The following is a description of a gene set: Reactome Pathway: Glutamate binding, activation of AMPA receptors and synaptic plasticity studied in species Homo sapiens Excitatory synaptic transmission in the brain is carried out by glutamate receptors through the activation of both ionotropic and metabotropic receptors. Ionotropic glutamate receptors are of three subtypes based on distinct physiologic properties and their differential binding of exogenous ligands namely NMDA (N-methyl D-aspartate), AMPA (alpha-amino-3-hydroxy-5-methyl-4-isoxazolepropionic acid) and Kainate. The ionotropic receptors are glutamate gated ion channels that initiate signaling by influx of ions, and are comprised of subunits with distinct structures and distinguished based on their agonist binding. Even though all three types of receptors are found at the glutamatergic synapses yet they exhibit great diversity in the synaptic distribution. The metabotropic glutamate receptors are a family of G-protein coupled receptors that are slow acting. Fast excitatory synaptic transmission is carried out through AMPA receptors. Post-synaptic transmission involves binding of the ligand such as glutamate/AMPA to the AMPA receptor resulting in the Na influx which causes depolarization of the membrane. NMDA receptors are blocked by Mg at resting membrane potential. NMDA receptors are activated upon coincident depolarization and glutamate binding are activated following AMPA receptor activation.NMDA receptors are blocked by Mg at resting <br>membrane potential. NMDA receptors are Ca permeable and their activity leads to increase in Ca which, leads to upregulation of AMPA receptors at the synapse which causes the long lasting excitatory post-synaptic potential (EPSP) which forms the basis of long term potentiation (LTP). LTP is one form of synaptic plasticity wherein the strength of the synapses is enhanced by either change in the number, increase in the efficacy by phosphorylation or change in the type of receptors. Phosphorylation of AMPA receptors changes the localization of the receptors, increases the single channel conductance, and increases the probability of open channel. GluR1 has four phosphorylation sites; serine 818 (S818) is phosphorylated by PKC and is necessary for LTP, serine 831 (S831) is phosphorylated by CaMKII that increases the delivery of receptors to the synapse and also increased their single channel conductance, threonine (T840) is implicated in LTP. Serine 845 (S845) is phosphorylated by PKA which regulates open channel probability. Long term depression is another form of plasticity wherein the number of AMPA receptors is diminished by either phosphorylation of GluR2 at Ser880 or dephosphorylation of GluR1 by protein phosphatase1, protein phosphatase 2A and protein phosphatase 2B (calcineurin). part of: Neurotransmitter receptors and postsynaptic signal transmission, and this is the list of marker genes: EPB41L1, PICK1, PRKCG, CACNG3, GRIP1, AP2S1, GRIA2, CAMK2G, CAMK2B, CACNG8 (NCBI Gene Id 59283), PRKCA, CACNG4, AKAP5, GRIA4, GRIA1, MYO6, CAMK2A, AP2M1, CACNG2, PRKCB, TSPAN7, AP2B1 (NCBI Gene Id 163), MDM2, AP2A1, CAMK2D, DLG1, DLG4, NSF, AP2A2 (NCBI Gene Id 25955), GRIP2, GRIA3